The following is a description of a gene set: Mouse Gene Set: GOCC_MCM_COMPLEX studied in species Mus musculus A hexameric protein complex required for the initiation and regulation of DNA replication., and this is the list of marker genes: Mcm3, Mcm6, Tonsl, Mcm9, Mcm8, Mcm7, Mcmbp, Mcm5, Mms22l, Mcm4, Mcm2